Given this list of marker genes LMNB2, IFI35, PRIM1, CCRL2, TNFRSF1B, FBXO5, BHLHE40 (NCBI Gene Id 8553), MRPL48, HAUS4, AAMDC, TNFRSF8, CD244, CX3CR1, CCR5, MPDU1, IFITM1, CRELD2, KIFC1 (kinesin family member C1), COQ2, HLA-DRA, CTDSP2, PSMA6, CD36, MVB12B, CCDC28B, GCDH, ZBTB32, PIP4K2A (phosphatidylinositol-5-phosphate 4-kinase type 2 alpha), RAD54B, MACROH2A1, MRPL11, ETFDH, LSM5, RFXANK, KLHDC3, TAPBP, GRN, ANP32E, MZT2B, PPT1, CCR6, SEH1L, DCXR, DEK, ENTPD1, MT1E, PRMT7, PSMA4, EGR1, TOX, SLC24A3, CCT4, NPC2, RPS2, LDLR, CTSH, SPDL1, DTYMK, HLA-DRB6, MIS18A, RPP30, TACC3, CTPS2, SLC27A2, DPYSL2, SFPQ, IL18R1, BIRC5, DAZAP1, ME2, CEBPD, ACSL5, SRSF9, ALG6, RANBP1, WDR12, CYRIB, KIF14, FDFT1, HNRNPAB, FTH1, CD74, CD9, SNX10, IRF1, EMC9, CD38, HPRT1, KIR3DS1 (NCBI Gene Id 3813), PSMG1, SPAG9, BUB3, SRRT, GGCT, EZH2, KIF18A, DESI2, NUP88, PRKCB, CTDSPL, PDXK, FDPS, POMP (proteasome maturation protein), H1-10, LILRA2, POLR3K, CLU, KIR2DS1, RAN, KIR2DS5, OTULINL, CD93, SHQ1, CDC7, ENO2, RFC2, PRKCQ, CD58, PIR, ATP2A2, SRSF2, TRPS1, MT1H, JPT2, SP140, PSMD13, GPR137B (NCBI Gene Id 7107), NCR3, TRIM5, H2AX, SPRY1, SFN, TCP1, RALY, SQOR, GYG1, PSMC4, CHAF1A, UCK2 (uridine-cytidine kinase 2), PTBP1, SHCBP1, RAB9A, PSRC1, NCAPD3 (non-SMC condensin II complex subunit D3), IDI1, TBX21, MCM3, IL3RA, LXN, MFSD1, TUBA1A, SETBP1, CTPS1, NUDT1, UBAP2L, MSRB2, NHERF1, KLRB1, MBD4, KCNN4, CD59, RPSA, NUP54, KIR3DL3, NDRG1, SCPEP1, GIMAP4, DDX39A, FYN, SLC27A3, RFC5, DKC1, WEE1, YWHAH, CHEK1, SRF, PIH1D1, UQCRH, UCHL1, NCAPH, OIP5, ARHGAP19, SLC7A1, ARID5B, RBMX, TOM1L1, TAX1BP3, IL15, KIR2DL5A, UBXN8, IFITM3, CLIC1, HEXB, SNRPE, ECI2, MRPL16, RBM12, TTK, HMGB3, PDGFRB, here is a description of the gene set: from publication Matsushima H, Geng S, Lu R, Okamoto T, Yao Y, Mayuzumi N, Kotol PF, Chojnacki BJ, Miyazaki T, Gallo RL, Takashima A (PMID 23305731) species: Homo sapiens To investigate the functional properties of Ly6G+ DC, we employed GeneChip analysis to compare the gene expression profiles between Ly6G+ DC and Ly6C- DC. Genes down-regulated dendritic cells: Ly6G+ versus Ly6G-. Human Gene Set: GSE28408_LY6G_POS_VS_NEG_DC_DN